The following is a description of a gene set: Cytokines mediate cell-cell communication in the immune system and represent important therapeutic targets. A myriad of studies have highlighted their central role in immune function, yet we lack a global view of the cellular responses of each immune cell type to each cytokine. To address this gap, the authors created the Immune Dictionary, a compendium of single-cell transcriptomic profiles of more than 17 immune cell types in response to each of 86 cytokines (>1,400 cytokine-cell type combinations) in mouse lymph nodes in vivo. A cytokine-centric view of the dictionary revealed that most cytokines induce highly cell-type-specific responses. For example, the inflammatory cytokine interleukin-1β induces distinct gene programmes in almost every cell type. A cell-type-centric view of the dictionary identified more than 66 cytokine-driven cellular polarization states across immune cell types, including previously uncharacterized states such as an interleukin-18-induced polyfunctional natural killer cell state. Mouse Gene Set: CUI_ILC_IL1A_RESPONSE_DN from publication Cui A, Huang T, Li S, Ma A, Pérez JL, Sander C, Keskin DB, Wu CJ, Fraenkel E, Hacohen N (PMID 38057668) Genes negatively differentially expressed in cell type: ILC (innate lymphoid cell) upon treatment with cytokine: IL-1α in mouse lymph nodes in vivo. species: Mus musculus, and this is the list of marker genes: Il18r1, Sptssa, S100a6, Ltb (NCBI Gene Id 16994), S100a4